Given this list of marker genes MEX3B, EHMT2, ZEB2, EPHA5 (EPH receptor A5), PKN2, FERRY3, ZBTB4, ENPP2, TNFSF14, RBPMS, SNRNP27, SLC2A12, PDGFB, SLC40A1, CCR3 (NCBI Gene Id 1232), CRK, STAR, FBXL7, ZNF416, DHRS7, MLKL, GRID2, NAA30, PRAMEF5, TXK, SH3RF1, RRAGB, WDR33, SFTPB, SGK1, TMBIM1, ZNF436, TCEAL1, ITPRID2, TMEM120A, PABPC4L, COLEC10, MGST1, ZFX, KMT5B, TNRC6B, ATRN, NRXN1, DSCAM, PERP, MACROH2A2, RAB14, C20orf173, TYW3, BPNT2, RLN2, FOXP3, MINDY2, CREBRF (NCBI Gene Id 153222), ZFAND3, NRIP1, FHL5, PRAMEF6, DCAF10, NUFIP2, ZBTB20, GLUL, SLC25A3, LRRC8C, GK, CCDC175, KIF23, FMNL3, STK36, NCAN, NUBPL, LAP3, KLF6, BACH2, ATF2, CALM1, SEMA3D, LHX1, RASAL2, VXN, SYT9, ADGRA1, SLC36A2, SEPTIN3, AKIRIN1, UBE2J1, KIF20A, ABHD17C, TMEFF2 (NCBI Gene Id 51753), LAX1 (lymphocyte transmembrane adaptor 1), PRAMEF25, ANTXR1, PPAT, KRTAP9-9, IGF2, CHM, HTR2C, PRAMEF11 (NCBI Gene Id 440560), ARL13B, LSAMP, ABO, YAE1, TSHZ1, PRAMEF4, ADORA3, PGM5, CISD2, SLC12A2, EDNRB, UFL1, BDH2, TFEC, CCDC14, PIN4, HSD3B2, FZD6, PRAMEF15, CLEC4C, RLN1, TTI1, MAPK6, FLRT2, SLC26A7, here is a description of the gene set: studied in species Homo sapiens from publication Chen Y, Wang X (PMID 31504780) Genes predicted to be targets of miRBase v22 microRNA hsa-miR-6818-5p in miRDB v6.0 with MirTarget v4 prediction scores > 80 (high confidence targets). Human Gene Set: MIR6818_5P